The following is a description of a gene set: Human Gene Set: GSE8685_IL2_STARVED_VS_IL21_ACT_IL2_STARVED_CD4_TCELL_UP studied in species Homo sapiens from publication Marzec M, Halasa K, Kasprzycka M, Wysocka M, Liu X, Tobias JW, Baldwin D, Zhang Q, Odum N, Rook AH, Wasik MA (PMID 18281483) Genes up-regulated in Sez-2 cells (T cell lymphoma): untreated versus IL21. In this study we compared the effects of IL-2, IL-15, and IL-21 on the gene expression, activation of cell signaling pathways, and functional properties of cells derived from the CD4+ cutaneous T-cell lymphoma (CTCL). Whereas both IL-2 and IL-15 that signal through receptors that share the common gamma chain and the beta chain modulated the expression of >genes, IL-21 that signals via the receptor also containing gamma chain up-regulated <genes. All three cytokines induced tyrosine phosphorylation of Jak1 and Jak3. However, only IL-2 and IL-15 strongly activated STAT5, PI3K/Akt, and MEK/ERK signaling pathways. In contrast, IL-21 selectively activated STAT3. Whereas all three cytokines protected CTCL cells from apoptosis, only IL-2 and IL-15 promoted their proliferation. The effects of the cytokine stimulation were Jak3- and Jak1-kinase dependent. These findings document the vastly different impact of IL-2 and IL-15 vs. IL-21 on malignant CD4+ T cells. They also suggest two novel therapeutic approaches to CTCL and, possibly, other CD4+ T cell lymphomas: inhibition of the Jak1/Jak3 kinase complex and, given the known strong immunostimulatory properties of IL-21 on CD8+ T, NK, and B cells, application of this cytokine to boost an immune response against malignant CD4+ T cells., and this is the list of marker genes: SSX2IP, TSPAN4 (tetraspanin 4), ARHGAP29, BCL2L2, C4orf19, FGD2 (NCBI Gene Id 221472), RANBP1, FBF1, SOX21, SNHG32, PAIP1, EIF4A2, MRE11, VPS26A, CILK1, NKRF (NFKB repressing factor), EGF, GMDS, NYX, CDK18, INSR, MEGF8, CHPT1, PTGDS, BAG2, ZNF280D, NAT10, CACHD1, ADCY9, RTL6, LRPPRC, ARHGAP11A, TDRKH, RPS6, CREB3L3, RERE, PRDM5 (NCBI Gene Id 11107), BET1, KDM8, FZD6, ZC3H7A, VAPA, DDX3X, CPSF7, MGAT2, AGL, ARL6, PPM1E, ACP1 (acid phosphatase 1), UROS, FPGS, CEP128, PKN2 (NCBI Gene Id 5586), ASS1, PLXNB2, STOML2, ANO6, GFI1, HDAC9, IREB2, OSGIN2, TPD52, SNX30, GLA, CPD, OAS2, ABHD15, MAPK8, ZC3HAV1L, SETDB1, IFT88, ATP1B2, ACAP2, RALGPS2, TSNAX, ZNF446, ZDHHC13, PXK, NAT8L, STAU2, TRIM35, EIF4H, CHEK2, ALKBH1, IL11RA, DNPH1, SSBP1, DHX33, RIOK3, PCK2, BCR, MPP7, VKORC1L1 (NCBI Gene Id 154807), B3GALNT1, MGST2, PCCA, TMEM119, QTRT1, MLH1, RFX5, NQO1, CASP12, SRSF6, RENBP, SLCO1C1, OCIAD2, RNF144B, ZRANB2, RP2, TGIF1, PUS10, ZNF131 (zinc finger protein 131), TSPOAP1, TNPO1, SLC40A1, KIF1B, CNR2, GNG10, UBA5, PRPF3, BLZF1, ST6GALNAC4, SRSF2, NUP43, SLC7A7, RABL2A (RAB, member of RAS oncogene family like 2A), ALG2, HNRNPUL2, ZC3H8, CRYZ, NLE1, CSTPP1, LTBR, CFAP69, G6PD, FNBP4, ACTG2, OSBP, NOLC1, PRICKLE1, GCNT2, FASTKD3, ERCC5 (ERCC excision repair 5, endonuclease), LHPP, CCNE2, NCOR1, SNX8, YTHDF2, CEP131, DNAJB9, ALCAM (NCBI Gene Id 214), POLR3E, MTX2, FAM135A, UTP14A (NCBI Gene Id 95977), CUTC, GLOD4, MAPK14, CLU, ERMP1, SMIM5, CYSLTR1, CHEK1, TIMELESS, CPN1, RIPOR1 (RHO family interacting cell polarization regulator 1), KLHDC10, GOLIM4, CCDC90B, PPFIBP1, UTP25, ZNF667, PLCB1, CPNE2, PYGL (glycogen phosphorylase L), SPAG4, PUS7, UNC93B1, CMTM8, TDRD3, ADSS2, LHFPL2, COQ2, SMARCC1, LMX1A, PAXBP1, IL6R, SLC22A3, ALG6, ZBED5, CEP57L1, R3HDM1, PAQR3, NPM1, ORC1, CUL4A, LIPT1, SCLT1, PSME4, INO80D